The following is a description of a gene set: Any process which produces a nucleotide, a nucleobase linked to either beta-D-ribofuranose (ribonucleoside) or 2-deoxy-beta-D-ribofuranose (a deoxyribonucleotide), from derivatives of it without de novo synthesis. Human Gene Set: GOBP_NUCLEOSIDE_SALVAGE studied in species Homo sapiens, and this is the list of marker genes: APRT, HPRT1, TK2, PRTFDC1, PGM2, QNG1, PNP, MTAP, DCTD, ADK, DNPH1, UCKL1